The following is a description of a gene set: Mouse Gene Set: GOMF_PROTEIN_N_TERMINAL_AMINO_ACID_ACETYLTRANSFERASE_ACTIVITY studied in species Mus musculus Catalysis of the reaction: acetyl-CoA + an N-terminal L-alpha-aminoacyl- = CoA + H+ + N-terminal Nalpha-acetyl-L-alpha-aminoacyl-., and this is the list of marker genes: Naa80, Naa60, Naa12, Naa11, Nat9, Naa10, Naa20, Naa40, Naa30, Naa50